The following is a description of a gene set: studied in species Homo sapiens The expansion of a T cell population by cell division. Follows T cell activation. Human Gene Set: GOBP_T_CELL_PROLIFERATION, and this is the list of marker genes: VTCN1, ZP3, LGALS9, FKBP1B, DLG5, PLA2G2F, HLA-G, NR5A2, IL23A, CD86, PRNP (NCBI Gene Id 96713), SCRIB, SHH, P2RX7, CD46, TNFSF13B, PTPRC (protein tyrosine phosphatase receptor type C), TGFBR2, IL6ST (interleukin 6 cytokine family signal transducer), RIPOR2, SYK, STAT5A, HLA-DPB1, DNAJA3, CCL5, PELI1, PNP, FADD, IGF2, IL21, IL1A (interleukin 1 alpha), LILRB4, TNFSF18, ARMC5, TNFRSF14, TMEM131L, IL2RA, EBI3, FYN, IL10, PPP3CB, BCL6, STAT5B, CEBPB, CTNNB1, LGALS9B, LILRB2, MSN, SCGB1A1, DHPS, CARD11, RC3H2, HAVCR2, PTPN6, TNFRSF9, LRRC32, BID (NCBI Gene Id 637), HES1, IL12B, TNFSF8, RIPK3, BMP4, BTLA, LMBR1L, IL23R, GPNMB, PRKAR1A, ELF4, PDCD1LG2, LGALS9C, SH3RF1, CORO1A, CD6, CD274, MALT1, BMI1, SLC11A1, PRDX2, ERBB2, RAC2, CCND3, KITLG, GPAM, NDFIP1, ARG1, SLC4A2, CASP3, CD55, IL4, TNFSF4, PRKCQ, EFNB1, MARCHF7, IL20RB, RASGRP1, SPTA1, CTLA4, MIR21, PIK3CG, IL18, CD37 (NCBI Gene Id 951), CD81, CD80, NCK2, NCSTN, EPO, GLMN, CD3E, HLA-E, PLA2G5, LEP, ZP4, MAPK8IP1, SDC4, TP53, ANXA1, PPP3CA, PLA2G2A (NCBI Gene Id 5320), ITCH, ZBTB7B, ZAP70, WNT4, IRF1, TNFSF9, IHH, HLA-DMB (NCBI Gene Id 3109), LILRB1, CCL19, SELENOK, IL4I1, PTPN11, DOCK8, ALKBH5, DOCK2, CADM1, RPS3, IGF1, SOS1, TNFSF14, LMO1, IL12RB1, TWSG1 (twisted gastrulation BMP signaling modulator 1), AIF1, SH2D2A, XCL1, ARG2, PAWR, TRAF6, HMGB1, NCKAP1L, IDO1, CD40LG, SFTPD, VSIG4, CD24, IL2, TNFRSF13C, MIR181C, BAX, CD151, RASAL3, TFRC, GNRH1, CLEC4G, HLA-DPA1, ABL1, CBLB, TGFB1, PYCARD, CLECL1P, RIPK2, FOXP3, TSPAN32, CD1D, CRTAM, VCAM1, TNFRSF1B, IL27, LIPA, BTN3A1, BTN2A2, ZNHIT1, TYK2, SLAMF1, IGFBP2, VSIR, NCK1, TMIGD2, IL1B, LAPTM5, HLA-A, SOS2, CD4, SLC7A1, TNFRSF4, AGER, ICOSLG (inducible T cell costimulator ligand), JAK2, LGALS3, CD28, BTNL2, CCR2, CR1, MYC, IL15, PSMB10, MIR30B (NCBI Gene Id 407030), MAD1L1, TNFRSF21, CD70, CD276, CDKN2A, HHLA2, PLA2G2D, SASH3, CLC, FOXJ1, HLA-DRB1, RC3H1, CD209, SPN, DLG1, CTPS1, IL6, CCDC88B